The following is a description of a gene set: species: Homo sapiens Any process that activates or increases the frequency, rate or extent of the regulated release of mucus from a cell or a tissue. Human Gene Set: GOBP_POSITIVE_REGULATION_OF_MUCUS_SECRETION, and this is the list of marker genes: P2RY2, PRKCE, CYBA, ATG5, ALOX12B